Given this list of marker genes HNRNPK, TWF1 (NCBI Gene Id 82712), PRKACB, RRM2, BLMH, XPO1 (exportin 1), CCNB1, KRAS, HMGN2, here is a description of the gene set: studied in species Homo sapiens Genes down-regulated in HCT116 cells (colon cancer) after treatment with amifostine depending on the presence of TP53: TP53-positive vs TP53-null cells. Human Gene Set: MANN_RESPONSE_TO_AMIFOSTINE_DN from publication Mann K, Hainaut P (PMID 15750621) The aminothiol WR1065 exerts selective cytoprotective effects in normal cells compared to cancer cells and has clinical applications for the protection of normal cells in cancer patients undergoing radio- or chemotherapy. There is evidence that p53 is activated in response to WR1065. To examine the effects of WR1065 on the signalling pathways controlled by p53, isogeneic human colon carcinoma cell lines (HCT116) differing only in the presence or absence of wild-type p53 were used. Treatment with WR1065 resulted in G1 cell cycle arrest in the p53-positive cell line but not in the p53-negative cell line. Long-term exposure resulted in minimal apoptosis of either cell line. Changes in gene expression in p53-positive or -negative cells treated with WR1065 were examined using commercial human stress and cancer gene arrays (Clontech Atlas arrays). Genes found to be specifically upregulated in a p53-dependent manner included coproporphyrinogen oxidase, ICErel-II cysteine protease, macrophage inhibitory cytokine-1 (also known as placental transforming growth factor beta), S100A4, and Waf1/p21. However, most proapoptotic genes typically upregulated by p53 in response to DNA damage were not activated. These studies show that WR1065 specifically modulates a subset of p53 target genes in a colon carcinoma cell line, consistent with the observation that this agent elicits essentially p53-dependent, cell cycle arrest responses.